The following is a description of a gene set: studied in species Homo sapiens from publication Chen Y, Wang X (PMID 31504780) Human Gene Set: MIR34B_5P Genes predicted to be targets of miRBase v22 microRNA hsa-miR-34b-5p in miRDB v6.0 with MirTarget v4 prediction scores > 80 (high confidence targets)., and this is the list of marker genes: PUM1, ACTL6A, MAPK1IP1L, CD40LG, STK39, THRB, DAAM1, MTDH, QDPR, SLC25A13, PFKFB1, HOXB8, ELAVL1, ADD2, PRKAA2, AHCYL2, CTNND2, FBXO45, IL1RAP (NCBI Gene Id 3556), GSK3B, DGKI, ASCL1 (NCBI Gene Id 429), PIK3C2A, CYRIB, NFAT5, STMN2, STK38L, RHOH, ATP6V0A2, ARID2, SLC25A36, DNM1L, CNTNAP1, CELF2, SMPD1 (sphingomyelin phosphodiesterase 1), HTR2C, AMER1, PYGB, RAP1GAP2, RDX, XKR6, RFX3, TENM1, PARD3, MAN2A2, KCNA1, APH1A, LYST, NEUROD1, DENND1B, MTCL1, FUT9, MTCL2, PHF6, HOXC8, RALA, GTF3C2, MIDEAS, CBLB, SNIP1, ASPHD2, PIEZO2, FKBP1B, MYCBP2, CEP55, GAS1, TENT4A, MAP3K9, PTPRG, MLLT3, KCTD16, PTPN4, MARVELD2, WIPF3, FAM219A, CAMSAP2, JAKMIP1, ZBTB34, MAPK4, ZC3H12B, CLDN8, RAB3C, ARID1B, PLEKHA1, APOB, TSPYL4, NDRG1, FBXO40, CELSR3, ANKS1B, APPL1, ERLIN1, GRHL1, TOX (NCBI Gene Id 9760), CDK19, MYC, THAP12, PTP4A2, DEFB134 (NCBI Gene Id 613211), CADM2, MET, ELMOD1, PHACTR1, TMCC3, MYF5, YWHAZ, BRPF1, NCOR1, HMBOX1, DLL1, ZC4H2, ATP11C, ZNF597, NEXMIF, TFDP2, VAMP3, DLG1, CREB1, NHSL1, BACE1, TASOR, FBXW10B, ZZZ3, SOX6, PAPSS2, MTF1, ATP1B3, LCP1, ETS1 (NCBI Gene Id 2113), KRTAP3-1, TMEM19, USP15, CALN1, HDGFL2, ATAD2B, HMGN4, IFIT1B, CNTN3